Given this list of marker genes CRHR1, GNB5, CBARP, CALM1, FMR1, GPR35, CACNA1F, CALM3, here is a description of the gene set: species: Homo sapiens Any process that stops, prevents or reduces the frequency, rate or extent of voltage-gated calcium channel activity. Human Gene Set: GOBP_NEGATIVE_REGULATION_OF_VOLTAGE_GATED_CALCIUM_CHANNEL_ACTIVITY